The following is a description of a gene set: species: Homo sapiens Human Gene Set: GOMF_EPOXIDE_HYDROLASE_ACTIVITY Catalysis of the reaction: an epoxide + H2O = an ethanediol., and this is the list of marker genes: EPHX2, EPHX1, ALOX12, EPHX3, LTA4H, RNPEP, EPHX4, AKR7A2